Given this list of marker genes NRG2, ERBB2, AKT3, JUN, SHC3, CDKN1A, MAPK8, BAD, CAMK2B, RPS6KB2, AKT1, KRAS, PAK5, BCL2L11, HBEGF, FOXO1, MAPK9, CAMK2G, PDPK1, MAP2K1, PAK1, TGFA, MAP2K7, ABL1, RPS6KB1, PRKCG, MAPK10, GSK3B, PIK3R1, PIK3CD, AREG, MAP2K2, MIR21, CBLB, EGFR, SHC4, EIF4EBP1, CCND1, MYC, CRK, MAP2K4, RAF1, NRG3, NRG4, SHC1, STAT5A, NCK1, GRB2, PTK2, AKT2, MAPK3, NRAS, SOS2, BTC, PRKCB, PIK3CB, PIK3CA, SOS1, ELK1, STAT5B, CAMK2D, ABL2, GAB1, PAK2, PIK3R2, ARAF, CBL, MAPK1, EGF, MTOR, NCK2, MDM2, PIK3R3, ERBB3, PAK3, SHC2, CAMK2A, BUB1B-PAK6, EREG, CDKN1B, PAK4, NRG1, PLCG2, BRAF, PAK6, CRKL, PRKCA, TP53 (tumor protein p53), ERBB4, SRC (SRC proto-oncogene, non-receptor tyrosine kinase), PLCG1, HRAS, here is a description of the gene set: ErbB signaling species: Homo sapiens Human Gene Set: WP_ERBB_SIGNALING